The following is a description of a gene set: Mouse Gene Set: GOBP_CELLULAR_RESPONSE_TO_OXIDATIVE_STRESS Any process that results in a change in state or activity of a cell (in terms of movement, secretion, enzyme production, gene expression, etc.) as a result of oxidative stress, a state often resulting from exposure to high levels of reactive oxygen species, e.g. superoxide anions, hydrogen peroxide (H2O2), and hydroxyl radicals. species: Mus musculus, and this is the list of marker genes: Mb, Prdx1, Bnip3, Snca, Cul3, Pdk2, Ncoa7, Stk26, Aifm1, Psap, Hdac6, Mpo, Mdm2, Ezh2, Trpa1, Pml, Cat, Sphk1, Stk24, Sirt2, Selenos, Keap1, Hspb1, Rhob, Trap1 (NCBI Gene Id 68015), Crygd, Tet1, Nos3, Brf2, Rbx1, Xbp1, Fxn, Mapk9, Hsf1, Gpr37l1, Oxr1, Smpd3, Arnt, Cd36, Ep300, Alox5, Ppia, Rps3, Trpm2, Tsc1, Sesn2, Akr1b1, Wnt16, Mpv17, Kdm6b, Atf2, Gsr, Trex1, Mmp3, Fyn, Mapk1, Pdcd10, Nme8, Endog, Oser1, Sirpa, Cygb, Klf2, Gpr37, Naglu, Ect2, Stau2, Mapk7, Fads2 (fatty acid desaturase 2), Edn1, Atf4, Chchd2, Met, Klf4, Rwdd1, Foxo3, Anxa1, Pjvk, Pycr1, Prdx5, Cfl1, Aifm2, Plekha1 (pleckstrin homology domain containing, family A (phosphoinositide binding specific) member 1), Ambp, Gpx5, Aldh3b1, Eif2s1, Ngfr, Pdgfra, Mgat3, Cryge, Pex12, Agap3, Abcd1, Btk, Ptprk, Fut8, Apoa4, Aif1, Pyroxd1, Arl6ip5, Rad52, Sirt1, Txn1, Park7, Prkn, Jun, Fancc, Meak7, Pycr2, Dhfr, Top2b, Tmigd1, Ppif, Hk3, Prkd1, Romo1, Txndc2, Rnf146, Prdx2, Il18rap, Crygf, Mmp9, Tldc2, Scly, Pink1, Coq7 (demethyl-Q 7), Reg3b (NCBI Gene Id 18489), Zfp277, Ggt1, Ppargc1a, Pdgfrb, Rbm11, Chchd4, Mapk8, Cyp1b1, Dhrs2, G6pd2, Sod1, Mt3, Slc25a24, Zfp580, Fancd2, Pawr, Ednra, Slc25a14, Stx2, Bmal1, Mmp2, Ppef2, Apex1, Capn1, Mapk13, Fabp1, Lonp1, Trp53inp1 (transformation related protein 53 inducible nuclear protein 1), Pex14, Foxo1, Akt1, Tbc1d24, Axl, Chchd2-ps, Ddr2, Aqp1, Lrrk2, Map2k4, Trp53, Egfr, Becn1, Ccs, Srxn1, Prkaa1, Slc1a1, Slc4a11, Slc7a11, Src, Stat6, Pdgfd, Prkaa2, Vrk2, Hdac2, Mapk3, Slc11a2, Tmem161a, Ankzf1, Vkorc1l1, Prkra, Selenon, Ripk3, Etv5, Pex13, Hif1a, Fos, Cbx8, Hspa8, Stk25, Sod2, Cdkn2a, Nfe2l2, Atg7, Cst3, Ogg1, Rack1, Htra2, Kat2b, Map3k5, Ppargc1b, Setx, Adprs, Abl1, Tnfaip3, Foxp1, Bmp4, Chuk, Prdx3, Atp2a2, Trpc6, Ern1, Prkcd, Msra, Ercc6l2, Nr4a2 (nuclear receptor subfamily 4, group A, member 2, NCBI Gene Id 18227), Stx4a (syntaxin 4A (placental)), Sod3, Sirt6, Nfe2l1, Zc3h12a, Net1, Lcn2, Gata5, Pex10, Fer, Atp13a2, Nqo1, Atp7a, Pex2, Gjb2, Cdk1, Ddias, Gch1, Ermp1, Pcgf2, Ngb, Ucp1, Parp1, Prr5l, Hgf, Pnpla8, Ripk1, Slc8a1, Pla2r1, Mapkap1, Dapk1, Foxa1, Pcna, Map1lc3a, Penk, Pex5, Sin3a, G6pdx, Pnpt1, Il6, Rela, Atm, Mgst1, Fbln5